The following is a description of a gene set: Genes up-regulated in CD4 T conv over-expressing IKZF2 versus IKZF2 and FOX3P. The transcription factor FoxP3 partakes dominantly in the specification and function of FoxP3+ CD4+ T regulatory cells (Tregs), but is neither strictly necessary nor sufficient to determine the characteristic Treg transcriptional signature. Computational network inference and experimental testing assessed the contribution of several other transcription factors (TFs). Enforced expression of Helios or Xbp1 elicited specific signatures, but Eos, Irf4, Satb1, Lef1 and Gata1 elicited exactly the same outcome, synergizing with FoxP3 to activate most of the Treg signature, including key TFs, and enhancing FoxP3 occupancy at its genomic targets. Conversely, the Treg signature was robust to inactivation of any single cofactor. A redundant genetic switch thus locks-in the Treg phenotype, a model which accounts for several aspects of Treg physiology, differentiation and stability. Human Gene Set: GSE40274_HELIOS_VS_FOXP3_AND_HELIOS_TRANSDUCED_ACTIVATED_CD4_TCELL_UP from publication Fu W, Ergun A, Lu T, Hill JA, Haxhinasto S, Fassett MS, Gazit R, Adoro S, Glimcher L, Chan S, Kastner P, Rossi D, Collins JJ, Mathis D, Benoist C (PMID 22961053) species: Homo sapiens, and this is the list of marker genes: CAMK2N1, CSRP2, PPP1R21, CAPN3, IFI27L2, DLX2, SHFL, TEC, MYO1C, NINJ1, IKZF3, BATF, TNIP1, SLC12A2, ANKRD23, NCF1, TMEM64 (NCBI Gene Id 169200), AP1M1, RPL13, KLF9, ARMCX4, MGST2, SLC19A2, AIDA, STAT5B, IRAG2, LTB, CTIF, TRAPPC6A, ASL, REPS1, TRAF1, PELI1, NRP2, SPTBN4, LACTB, ARRB1, KIT, EDEM2, ABCC1, FOXO1 (NCBI Gene Id 2308), CCL5, CCS, KLF3, FCRL1, PLEC, STAT5A, SLAMF1, PLA2G4F, ERBB2, SLC35D3, IRF5, IFNAR2, NCOA3, TMEM184B, SOCS5, BCAT1, PHACTR3, ENO3, RARG (NCBI Gene Id 5916), DMAC2L, SLC22A2, SSH1, TNFRSF4, C3orf80, EIF5A2, MGAT5, TXNRD3, GBP4, WDR59, ALCAM, YPEL3, TSPAN32, TRIM6, TEX48, STON1, CREBL2, NDNF, ST6GALNAC3, PTGER4, RNH1, IRF9, FBXO22, LOX, FBXO36 (NCBI Gene Id 130888), MIF4GD, CHRNB1, RB1, PPP1R3F, TDRD9, INPP5F, VCP, PIH1D1, PPM1B, CRIP1, SNX11, NSD3, ALDH16A1, TMEM175, AMFR, SELL, ADAMTS6, CYTH3, DYNC2H1, GRHL1, LETM2, RILPL2, STX11, ITGB7, CD38, CNDP2, NT5DC3, SH3RF1, GFOD1, GPR34, CTLA4, ITIH5, RGS1, PLAAT3, RTN4R, CPEB4, PLSCR1, SPRY1, USP11, SLC3A1, ENSG00000286190, BCAS1, COLQ, FAM234A, CATSPERD, IFT80, AHNAK, ATL3, RCN1, C1QL3, PDGFD, ANXA2, IL2RB, NKG7, TNFRSF25, GM2A, USF3, KMT2A (lysine methyltransferase 2A), RRAGD, DNAJA4, SLC4A7, DNAH8, CHCHD10, RORA, C1QTNF12, LTA, PTPRM (NCBI Gene Id 5797), TGIF1, MXD1, LRRK2, TRIM3, KRTCAP3, TOM1L2, ARHGEF3, MYO1E, JDP2, PLEKHG5, SESN1, GFI1, PIANP, LARP4, STAT4, HOOK2, NSMAF, GRSF1, CYBRD1, TTC39B, ABTB1, IGF2R, ST8SIA6, EEA1, CPLANE1, FBXO31, SLC22A17, CMTM7, YBX3, AP1M2 (adaptor related protein complex 1 subunit mu 2), CEP63, PLP2, IL15RA, SYNGR2, ADAMTSL4, REEP3, GSE1, SYTL1, SELPLG, CDK6, ITGAE, SPTB, C19orf12, P4HA1, EOMES, MYO1H, TENT5A, ARHGAP20